The following is a description of a gene set: Pathway Definition from KEGG: AGE -> AGER -> RAS -> RAF -> MEK -> ERK -> NFKB => (TNF,IL6,NOS2) Human Gene Set: KEGG_MEDICUS_REFERENCE_AGE_RAGE_SIGNALING_PATHWAY AGE-RAGE signaling pathway. Pathway ID: N00994. Pathway type: Reference. Pathway class: nt06460 Alzheimer disease. studied in species Homo sapiens, and this is the list of marker genes: BRAF, MAP2K1, NOS2, RELA, MAPK1, KRAS, TNF, MAPK3, RAF1, HRAS, NRAS, ARAF, IL6, NFKB1, MAP2K2, AGER